Given this list of marker genes LAMP5, LRRC17, HOXB6, SFRP4, CCN5, PPARG (peroxisome proliferator activated receptor gamma), LAMA2, PDCD4, G0S2, CIDEC, LMOD1, TIMP4, SVEP1, DUSP1 (dual specificity phosphatase 1), COL14A1, ELOVL2, ASPN, CXCL14, FAXDC2, OMD, ENPP2, DPT, ABCA8, TAT, TNN, ATRNL1, ITIH5, SPTAN1, GPD1, LEPR, AREG, GFRA1, MAOA, RAI2, RTN1, ZBTB16, ADIRF, CILP, HBB, NAT1, ESR1, F13A1, ADIPOQ (adiponectin, C1Q and collagen domain containing), SCUBE2, FABP4, IGF1, OGN, HOXB2, CFD, LEP (leptin), FBLN1, MFAP4, FOSB, PTN, NKX3-1, CHRDL1, PLIN1, PTHLH, MYH11 (myosin heavy chain 11), PTGER3, TNXA, CYP4B1, SLC26A3, PCSK5, ADRA2A, RBP4, LIPE, PGR, ITGA7, MYB, FHL1 (four and a half LIM domains 1), RUNX1, HMGCS2, ARMT1, C1orf21, PNMA2, ATP1A2, PSD3 (NCBI Gene Id 55358), BTG2, HLF, STC2, MAP3K12, CPA3, DHRS2, ADH1B, here is a description of the gene set: We explored whether the five previously reported molecular subtypes in breast cancer show a preference for organ-specific relapse and searched for molecular pathways involved. The intrinsic gene list describing the subtypes was used to classify 344 primary breast tumors of lymph node-negative patients. Fisher exact tests were used to determine the association between a tumor subtype and a particular site of distant relapse in these patients who only received local treatment. Modulated genes and pathways were identified in the various groups using Significance Analysis of Microarrays and Global Testing. Bone relapse patients were most abundant in the luminal subtypes but were found less than expected in the basal subtype. The reverse was true for lung and brain relapse patients with the remark that absence of lung relapse was luminal A specific. Finally, a pleura relapse, although rare, was found almost exclusively in both luminal subtypes. Many differentially expressed genes were identified, of which several were in common in a subtype and the site to which the subtype preferentially relapsed. WNT signaling was up-regulated in the basal subtype and in brain-specific relapse, and down-modulated in the luminal B subtype and in bone-specific relapse. Focal adhesion was found up-regulated in the luminal A subtype but down-regulated in lung relapse. The five major molecular subtypes in breast cancer are evidently different with regard to their ability to metastasize to distant organ(s), and share biological features and pathways with their preferred distant metastatic site. studied in species Homo sapiens from publication Smid M, Wang Y, Zhang Y, Sieuwerts AM, Yu J, Klijn JG, Foekens JA, Martens JW (PMID 18451135) Genes up-regulated in the luminal A subtype of breast cancer. Human Gene Set: SMID_BREAST_CANCER_LUMINAL_A_UP